Given this list of marker genes Rab27a, Cd244a, Ifnab, Ifna11, Ifna14, Gm13271, Ifna13, Gm13276, Cd160, Lamp1 (lysosomal-associated membrane protein 1), Ifna12 (NCBI Gene Id 242519), Ifna1, Fcgr4, Ifna4, Ifna7, Lgals9, Gm13272, Unc13d, Ap1g1, Gm13277, Gm13283, Ifnk, Ifna5, Gm13275, Coro1a, Ifna2, Ifna15, Nkg7, Ifna6, Ifnb1, Il12b, Ifnz, Ifne, Kctd9 (potassium channel tetramerisation domain containing 9), Stx11, Ifna9, Ifna16, here is a description of the gene set: Mouse Gene Set: GOBP_NATURAL_KILLER_CELL_ACTIVATION_INVOLVED_IN_IMMUNE_RESPONSE The change in morphology and behavior of a natural killer cell resulting from exposure a cytokine, chemokine, cellular ligand, or soluble factor, leading to the initiation or perpetuation of an immune response. species: Mus musculus